Given this list of marker genes STXBP1, LIN7C, OSBPL2, STXBP3, SYT4, RAP1BL, ADORA2A, CAMK2A, STX19, CACNA1B, SNAPIN, CPLX1, SLC32A1, SNPH, BRSK1, RIMS2, SYT11, FER1L5, GPER1, RIMS3, TACR2, SYT10, SEPTIN5, BGLAP, STXBP2, DOC2B, NAPA, SLC18A3 (solute carrier family 18 member A3), SYT13, FBXL20, SNCA, GRIK5, STX1B, PDZD11, CPLX3, CHRNA3 (NCBI Gene Id 1136), MCTP1, DOC2A, NLGN1, UNC13A (NCBI Gene Id 23025), UNC13C, PPFIA2, PIP5K1C (NCBI Gene Id 23396), RAB3GAP1, SYN2, SYNGR3, PRKCG, PFN2, SYT9, RAP1A, PPT1, SNCG, NPY, KMO, SYT1, GPR158, SLC38A2, SLC4A8, STX11, PRKN, SYT5, GIT1 (GIT ArfGAP 1), NRXN1, LRRK2, PTPRN2, RAB3A, PSEN1, SNAP23, CHRNB4, BEST1, SYN3, NGF, KCNMB4, SLC30A1, CADPS2, GGCX, P2RX1 (purinergic receptor P2X 1), SCRIB, FBXO45, SYN1, P2RX7, EFR3A (EFR3 homolog A), VPS18, RAP1B, DNAJC5, CPLX4, CPLX2, PRKCB, NF1, CASK, RPH3AL, SYT8, ABCC8, GPR151, WNT7A, ERC2, AP2B1, RAB5A, PPP3CA, CALM3, LIN7A, PREPL, OTOF, SLC6A9, PRRT2, MEF2C, SV2C, SNAP47, SNAP29, SV2B, STXBP5, MYOF, DYSF, CADPS, BAIAP3, SNCAIP, MICU3, SYT2, BRAF, SV2A, P2RY1 (NCBI Gene Id 90963), LIN7B, DVL1, SYT12, UNC13B, SYT7, RIMS1, MCTP2, ASIC1, HCRT, GRM4, STX1A, DTNBP1, CDK5, CSPG5, SNAP25, PPFIA3, TPRG1L, KCNJ8, NAPB, PCLO, RPH3A, BLOC1S6, SYNJ1, VAMP2, TSPOAP1, RIMS4, CACNB4 (NCBI Gene Id 785), HRH3 (histamine receptor H3), PNKD, STX2, SYP, FMR1, NRXN2, ATP2A2, here is a description of the gene set: Human Gene Set: GOBP_NEUROTRANSMITTER_SECRETION The regulated release of neurotransmitter from the presynapse into the synaptic cleft via calcium-regulated exocytosis during synaptic transmission. studied in species Homo sapiens